Given this list of marker genes Cited2, Zfpm2, Nr5a1, Dhx37, Sry, Wt1, Sema3a, Eif2s3y, Sox9, Dmrt1 (doublesex and mab-3 related transcription factor 1), here is a description of the gene set: Mouse Gene Set: GOBP_POSITIVE_REGULATION_OF_MALE_GONAD_DEVELOPMENT studied in species Mus musculus Any process that activates or increases the frequency, rate or extent of male gonad development.